The following is a description of a gene set: from publication Feuerer M, Hill JA, Kretschmer K, von Boehmer H, Mathis D, Benoist C (PMID 20231436) Human Gene Set: GSE20366_TREG_VS_NAIVE_CD4_TCELL_DEC205_CONVERSION_UP species: Homo sapiens Genes up-regulated in comparison of DEC-Pept Convert versus DEC-Pept CD25- (see Table 1S in the paper for details). Regulatory T (Treg) cells that express the FoxP3 transcription factor are essential for lymphoid homeostasis and immune tolerance to self. Other non-immunological functions of Treg cells, such as controlling metabolic function in adipose tissue, are also emerging. Treg cells originate primarily in the thymus, but can also be elicited from conventional T cells by in vivo exposure to low-dose antigen or homeostatic expansion, or by activation in the presence of TGFβ in vitro. Treg cells are characterized by a distinct transcriptional signature controlled in part, but not solely, by FoxP3. For a better perspective on transcriptional control in Treg cells, we compared gene expression profiles of a broad panel of Treg cells from various origins or anatomical locations. Treg cells generated by different means form different sub-phenotypes identifiable by particular combinations of transcripts, none of which fully encompass the entire Treg signature. Molecules involved in Treg effector function, chemokine receptors, and the transcription factors that control them are differentially represented in these subphenotypes. Treg cells from the gut proved dissimilar to cells elicited by exposure to TGFβ, but instead they resembled a CD103+Klrg1+ subphenotype preferentially generated in response to lymphopenia., and this is the list of marker genes: SIK1, ITGB8, RNF130, CBL, KCTD12, GOLM2, L1TD1, CXCL10, HLA-DOB, ZNF281, SMPX, VAV2, NEB, CCR6, SAMD8 (NCBI Gene Id 142891), SDHB, KLF4, GSTM4 (NCBI Gene Id 82153), CYBB, HBB, HLA-DRB1, GPX2, CNR2, SH3TC2, RRAD, CXCR5, LAD1, MGAT5, MTHFD2, HLA-DQA1, HLA-DMA, COL14A1, FBXO17, RRAGD (Ras related GTP binding D), AIG1, SERINC5 (NCBI Gene Id 256987), MNAT1, CACNA1D, P2RX7, FCMR, TFDP1, UTP6, PARD6G, GPHN, ESCO2, AIMP1, CDK6, RINT1, NT5DC3, MT1E, TNIK, NDRG1, NR1H4, NIBAN1, HIBADH, CTSS, TNFRSF4, RPL32, RAB34, INPP5F, GPR83, ELP5, DENND5A, CEMIP, SULT2B1, PDGFRA, EIF4E3, KLF11, KIF12, NCEH1, CD81, SLC7A7, CC2D2A, PIP5K1A, SAMTOR, CNKSR3, RGS10, AXL, VEZF1, JUN (NCBI Gene Id 3725), ARHGAP17, GZMB, HEPACAM, TRIM32, TMBIM4, SLC16A9, GPX7, LRRC61, MRNIP (MRN complex interacting protein), PHC3 (NCBI Gene Id 80012), IMMP2L, FOXP3, ITIH5, IFT80, ETS2, BCL2L1, FRMD6, LAMP1, AOPEP, ICAM1, NPC2, SNX18, ADAM17, CTSV, VSTM5, STAM2, PHLPP1, PRKCI, NETO2, MN1, ATP1B1, ZNF23, RAB20, TREML2, MRC1, RNF144B, CYTH1, ADAMTS6, IFNGR2, PMEPA1, RWDD3, EPHX1, IL2RA, C3orf70, PIK3AP1, IKZF4, H2BC5, LEMD1, SH3PXD2A, P4HA1 (prolyl 4-hydroxylase subunit alpha 1), RAB39A, SLC35D1, COX6B2, NTN4, GBP4, ARHGAP20, LTA4H, TRAF1, RREB1, TOB2, SYTL2, SELL, UNC5CL, ATXN7, IL10, SIGMAR1, RCN1, SWAP70, SEC22C, PPM1L, GPR34, ITGA6, NEDD4L, ADAM19, LDLR, ACSBG1, INPP4B, DNAH7 (dynein axonemal heavy chain 7), CBFA2T2, CD300A, GADD45B, CASP6, CKS1B, TLE1, DENND4A, FAM53C (NCBI Gene Id 51307), CRELD1, CD72, NUAK2, GPR146, MSI2, TRAF4, DNAJC16, ADORA1, SRC, STON1, CENPH, NXPE4, TNFRSF9, MAGED2, MCOLN3, PI4K2B, CXCL3 (NCBI Gene Id 2921), WDR82, CAMKK1, FGL2, LRRCC1, FAM3C, BPNT1, SESN1, TNFRSF18, SLC16A6, IGF2R, COMMD1, PTGS1 (NCBI Gene Id 5742), CD83, FAM98B, ACER3, CISH, SLC2A3